Given this list of marker genes SYT2, C1GALT1, MAGEC1, USP1, ADIPOR1, ADGRA1, MAP6, MYL9, NUGGC, ADGRL1, TRAF7, ATP11A, RORC, ATP8A1, UNC13A, FOXI2, SHLD1, POLR3B, FBXO36 (F-box protein 36), TRIOBP, CORO1A, ZDHHC11, GRIK2, RSPO4, RPH3AL, PMS2 (PMS1 homolog 2, mismatch repair system component), ATCAY, EIF3A, NECTIN1, CHD2, SMO, JAM2, TRPV3, CCDC28A-AS1, INHBB, CNNM1, FBXL20, DHRS12, SLC12A8, NBEA, SCYL1, HDAC11, DESI2, DDX24, DEPDC5, ANKRD34A, TNNI1, SLC29A4, CAPNS1, MYO5A, RUSF1, RPL23A, AQP9, PAPPA, ADAMTS9, DIABLO, SLC47A1, GFRA3, LRTM2 (NCBI Gene Id 654429), ULK4, MRPS16, BTN2A2, NFIC, PODN, CDC14A, GPAM, TMEM43, EHD2, TP53I11, TBX15, VASP, CAMK2B, DTX4, PITPNM1, HAPSTR1, RERE, CREBBP, RTL5, FBXL7, PDE3A, ZKSCAN8, FRZB, SLC8A2, TFDP2 (transcription factor Dp-2), GSE1, SLC9A8, ZNF624, CPAMD8, CASP14, ITPRIPL2, FGFRL1, MYL1, DUSP18, DPYSL2, ZC3H6, POU2F2, TRARG1, CDC20B, ST6GALNAC3, TAF2, NLRP5, BTN2A1, CHD3, SLC7A1, ZMIZ1, IGLON5, ZC3H4, EPB41L1, GLIS3, here is a description of the gene set: Human Gene Set: MIR4455 species: Homo sapiens from publication Chen Y, Wang X (PMID 31504780) Genes predicted to be targets of miRBase v22 microRNA hsa-miR-4455 in miRDB v6.0 with MirTarget v4 prediction scores > 80 (high confidence targets).